The following is a description of a gene set: part of: Selenoamino acid metabolism Methylseleninic acid (MeSeO2H) is reduced to methylselenenic acid (MeSeOH) and then further reduced to methylselenol (MeSeH) by thioredoxin reductase (TXNRD1). Reactome Pathway: Metabolism of ingested MeSeO2H into MeSeH species: Homo sapiens, and this is the list of marker genes: TXNRD1